Given this list of marker genes Fkbp1a, Tgfbr3, Adgrg6, Adamts1, Cav3, Fhl2, Srf, Bmp10, Egln1, Tek, Rbp4, Hey2, Nkx2-5, Ovol2, Smarca4, here is a description of the gene set: Mouse Gene Set: GOBP_HEART_TRABECULA_FORMATION The process of creating a trabecula in the heart. A trabecula is a tissue element in the form of a small beam, strut or rod. species: Mus musculus